Given this list of marker genes SERPINB1, NDUFA6, FAT4, PNMA8A, SLC24A3, SNRPD3, PEX11A, BLTP1, SLC47A1, C4orf3, here is a description of the gene set: An association between hormones and meningioma has been postulated. No data exist that examine gene expression in meningioma by hormone receptor status. The data are surgical specimens from 31 meningioma patients undergoing neurosurgical resection at Brigham and Women's Hospital from March 15, 2004 to May 10, 2005. Progesterone and estrogen hormone receptors (PR and ER, respectively) were measured via immunohistochemistry and compared with gene expression profiling results. The sample is 77% female with a mean age of 55.7 years. Eighty percent were grade 1 and the mean MIB was 6.2, whereas 33% and 84% were ER+ and PR+, respectively. Gene expression seemed more strongly associated with PR status than with ER status. Genes on the long arm of chromosome 22 and near the neurofibromatosis type 2 (NF2) gene (22q12) were most frequently noted to have expression variation, with significant up-regulation in PR+ versus PR- lesions, suggesting a higher rate of 22q loss in PR- lesions. Pathway analyses indicated that genes in collagen and extracellular matrix pathways were most likely to be differentially expressed by PR status. These data, although preliminary, are the first to examine gene expression for meningioma cases by hormone receptor status and indicate a stronger association with PR than with ER status. PR status is related to the expression of genes near the NF2 gene, mutations in which have been identified as the initial event in many meningiomas. These findings suggest that PR status may be a clinical marker for genetic subgroups of meningioma and warrant further examination in a larger data set. from publication Claus EB, Park PJ, Carroll R, Chan J, Black PM (PMID 18172325) Genes up-regulated in meningioma samples positive for PGR compared to those without the receptor. Human Gene Set: CLAUS_PGR_POSITIVE_MENINGIOMA_UP species: Homo sapiens